The following is a description of a gene set: studied in species Homo sapiens Human Gene Set: GSE14769_UNSTIM_VS_360MIN_LPS_BMDM_UP Genes up-regulated in comparison of unstimulated macrophage cells versus macrophage cells stimulated with LPS (TLR4 agonist) for 360 min. from publication Litvak V, Ramsey SA, Rust AG, Zak DE, Kennedy KA, Lampano AE, Nykter M, Shmulevich I, Aderem A (PMID 19270711) The innate immune system is a two-edged sword; it is absolutely required for host defense against infection, but if left uncontrolled can trigger a plethora of inflammatory diseases. Here we used systems biology approaches to predict and validate a gene regulatory network involving a dynamic interplay between the transcription factors NF-κB, C/EBPδ, and ATF3 that controls inflammatory responses. We mathematically modeled transcriptional regulation of Il6 and Cebpd genes and experimentally validated the prediction that the combination of an initiator (NF-κB), an amplifier (C/EBPδ) and an attenuator (ATF3) forms a regulatory circuit that discriminates between transient and persistent Toll-like receptor 4-induced signals. Our results suggest a mechanism that enables the innate immune system to detect the duration of infection and to respond appropriately., and this is the list of marker genes: ALDOA, PCNX1 (NCBI Gene Id 23690), SLC35B2 (NCBI Gene Id 347734), WDR75, PRADC1, SELENOK, DUT, PCCB, LSM3, ACADM, NQO2, KIAA0930, FRRS1, MRE11, COX7A2, USE1, SLC11A1, GAR1, MRPL41, PLEKHG3, CENPB, NCF2, MMD, NUDT21, PDE8B, PBDC1, EVI5, FAM78A, PSTK, MLF1, POLD1, ZRANB3, ALG8, SDCCAG8, ME2, POLA2, PDCL, TMEM81, UBE2E3, COA6, CD9, MERTK, EZH2, SLC41A2, EBPL, ITGAM, PAQR4, UQCC6, RFC4, ASF1B, PTGR1, USP14, B3GLCT (NCBI Gene Id 145173), ECH1, CCDC47, DERA, NUP205, GPR180, FAM32A, IFT80, ANGPTL2, VPS26C, SDHAF2, NUMA1, EMC3, MTR, PGD, ATP5F1C, TXNDC15, HIKESHI, NPM1, GSK3B, YBX1, MRPS6, NIFK, CNOT10, TUSC1, SNRPD2, PSMA1, RAD51, POP5, CEP78, BIVM, ROCK2, SPTLC1, PRPS1, TBC1D2, IMPDH2, TUBG1, NDUFAF7, RDH10, FAM162A, MBTPS1, RUSF1, ELAVL1, PRMT7, MEAF6, NSD2, DPY30 (NCBI Gene Id 84661), ERH, AKAP11, LEPROTL1, CLN8, TMEM208, DCAF7, ORC2, TBC1D5, SPDL1, NUDC, IGF1, MXD4, CPEB2, EFNB1, NARS2, AIMP2, ZDHHC3, IL11RA, THYN1, DHRS13, XRCC1, TOP2A, PAFAH1B3, MRPL18 (mitochondrial ribosomal protein L18), KLF4, UBE2S, PRDX3, POLR1G, MRPL11, PGLS (6-phosphogluconolactonase), RNF157, ABHD4, FAF1, PDLIM4, RNF141, ACOT11, RPS27L, KNL1, LETMD1, ITGB1BP1, ADSS2, DHX32, ZRANB2, MDH2, ZNF219, LIPA, VPS13B, HASPIN, GTF2E2, ING4, NAV2, PCED1B, SAP18, CTPS1, ALAD, C6orf118, NCBP1, PHB2, ZNF227, MCM4, PHTF1, PNPLA6, KCNAB2, TCEAL8, DOCK7, SLF1, USP8, PTPN18, SARS1, NDUFV3, FDPS, DHRS1, S100A6, STX19, RPL4, ACP6, SPC24, RHOA, MAF1, TRIB3, STMN1, PA2G4, FOXN3, INAFM1, HEATR3, ATMIN, ABCD4, APEX1, OXCT1, EIF5A2, CAMK1, SAMD1, OBI1, MFSD12, C1QTNF12, NDUFS5, OTUD6B, HSPA14, MCM6, MRPS12, STIL